Given this list of marker genes CCT3 (NCBI Gene Id 7203), TMCC2, ELAVL2, SRM, CCNK, CNNM3, ANP32A, BAZ1B, ZNF628-DT, POLR1D, NFYC, PSMB3, CHCHD7, RRAGC-DT, GOLPH3L, SETD3 (SET domain containing 3, actin N3(tau)-histidine methyltransferase), STARD7, DDA1, C2orf92, H4C4, POGZ, RPS6KA5 (NCBI Gene Id 9252), MIR3181, CYLD (CYLD lysine 63 deubiquitinase), BCAS3, ANKHD1-DT, IGSF9B, ZBTB20, ZFAND6, ACTL6A, DGLUCY, H4C2, TTBK2, ANKHD1-EIF4EBP3, ENSG00000275740, NUCKS1, LNX2, PPP2R5E, PLAG1, SCAI (suppressor of cancer cell invasion), CALR, WDTC1, ANKHD1, ZNF628, CREBRF, ARRDC3, USF3, WDTC1-DT, TSACC, H4C3, CYCS, ARRDC3-AS1, SSBP3, RRAGC, LINC02210, ZBED5-AS1, KANSL1, ZBED5, KPNB1, CHD6, MPRIP, ACTR1B, EHBP1, STT3A, NUMB, OXR1, LINC02210-CRHR1, CEP152, CDKL5, CENPF, RBM27 (NCBI Gene Id 54439), CHD8, here is a description of the gene set: Genes containing one or more binding sites for (ZNF622) in their promoter regions (TSS -1000,+100 bp) as identified by GTRD version 20.06 ChIP-seq harmonization. studied in species Homo sapiens from publication Yevshin I, Sharipov R, Kolmykov S, Kondrakhin Y, Kolpakov F (PMID 30445619) Human Gene Set: ZNF622_TARGET_GENES